The following is a description of a gene set: Human Gene Set: HP_CAUDAL_APPENDAGE Caudal appendage species: Homo sapiens The presence of a tail-like skin appendage located adjacent to the sacrum., and this is the list of marker genes: DCHS1, MASP1, TRPV4, COLEC11, COLEC10, FAT4